Given this list of marker genes Slc1a2, Gfap, Ntsr1, Slc1a1, Slc1a3, Prkcd, here is a description of the gene set: species: Mus musculus Mouse Gene Set: GOBP_D_ASPARTATE_TRANSMEMBRANE_TRANSPORT The process in which D-aspartate, the D-enantiomer of the anion of (2R)-2-aminobutanedioic acid is transported across a lipid bilayer, from one side of a membrane to the other, by means of some agent such as a transporter or pore.